The following is a description of a gene set: The two major human gd T cell subsets, Vd1 and Vd2, display differences in tissue tropism and agonist responses, but we have little insight into global differences that may exist at the gene expression level. This is due to the small numbers of these cells that can be obtained from healthy donors, which limit comprehensive, comparative gene expression analyses. We established a culture method that expands Vd1 and Vd2 cells from the same PBL preparation to levels sufficient for sorting and microarray analysis. Although the subsets were expanded identically (anti-TCR mAb, plus IL-15), 392 and genes were identified, which were differentially expressed in the two subsets, from two donors, respectively. Approximately genes changed in both subsets following PMA/ionomycin treatment; about 50% of these genes were subset-specific. Both subsets responded to a crude LPS preparation, but only 6% of the responsive genes were the same. The differentially expressed genes were consistent with Vd2 cells being more inflammatory and Vd1 cells having more of a regulatory phenotype. Both subsets expressed transcripts encoding an array of innate and NK cell receptors, supporting the relationship of gd T cells to the innate immune system. Our results show that circulating Vd1 and Vd2 subsets in humans have considerable, inherent differences in gene expression following treatment with non-TCR agonists, supporting unique functional roles for these cells in vivo. Human Gene Set: GSE3720_LPS_VS_PMA_STIM_VD2_GAMMADELTA_TCELL_UP studied in species Homo sapiens from publication Kress E, Hedges JF, Jutila MA (PMID 16423401) Genes up-regulated in Vd2 gamma delta T cells: LPS versus phorbol myristate acetate and ionomycin., and this is the list of marker genes: PTPN4, THBS4, FOXN3, MIR34A, HSD17B6, ADGRG3, ICA1L, ARL15, SF3B1, ITGA4, CDK2, CUL3, STARD10 (NCBI Gene Id 58501), RORA, AMY1A, PIEZO2, PDPN, CYP7A1, WDR35, THY1, ADRB2, DNAI4, TEF, CEP164, MIR491, LRRC3B (NCBI Gene Id 116135), N4BP2L2, KLRK1, TMPRSS13, IL18RAP, CCDC93, PNLIP, PDCD10, ATP8B4, KLRC1, ARHGAP26, TAX1BP3, SPN, HTR2C, CDHR1, STAG3, CLDND2, MMP25, ZBTB1, CROT, OVGP1, TLE2, CAND2, DPY19L1, OSBPL3, SNAPC3, TXNDC8, MAGEA5P, CHIT1, SLC5A3, GARIN2, HERC1, DGKH, ATP10D, LYRM4, NUP155, DMXL1, MACO1, MCTP2, BMAL1, FASTKD1, THADA, XRN1, GABBR1, DOCK10, OOSP1, CLOCK, ANXA1, TBCK, TPSB2, ESM1, LPIN1, RDM1, HNRNPH1, TTC39C, ZBTB41, LONRF3, MIR16-1, CDH17, GABARAPL1, FBXO11, NIPAL3, SLAMF1, TAF9B, S1PR5, PSME4, PPP4R3B, NCKAP1, ARHGEF12, HAVCR2, ENTPD1, CERS5, KCNJ8, AZI2, MORN3, CALCOCO2, NF1, IL1RL1, IRF4, AGTR2, GFI1B, LIPK, ACSS2, CRELD1, BHLHE40, NEBL, TMEM87B (transmembrane protein 87B), ERN1, MIR203A, ECM1, MAGEB18, ZC3H7A, ARMC7, GNGT1, GZMA, TMEM120B, THEMIS (thymocyte selection associated), TMEM62, GPR171, MYSM1, RPL39L, PPP1R3C, STEAP1, MC4R, IRF6, GALR2, DIPK1B (NCBI Gene Id 138311), ZEB2, CD80, DDIT4L, HEXIM1, DDX17